Given this list of marker genes VSTM2L, NEBL, KLK10, ALDH1A3, PLEKHA7, SLCO3A1, C1orf74, SLC6A14, CYP4B1, GRHL3, PLAAT3, EPB41L1, CLIC3, KRT78, ADAMTS9, SH3TC2, PINK1, OCLNP1, KRT4, IL1RN, CLDN7, PI3, S100P, APOBEC3A, ARHGDIB, CRCT1, SLC4A11 (solute carrier family 4 member 11), SPRR1A, PSCA, KRT7, KRT23, DAPP1, EPS8L1, TMOD3, ADGRF1, MALL, ELF3, SPRR3, VSIG10, VSIR, ERBB3, EGR3, GRHL1, FAM171B, SLC12A6, DKK1, CTSV, INPP4B, SAMD9, GGT6, A2ML1, TACC1, VGLL1, CST6, SOX9, TRIM2, RHBDL2, DSC2, GDPD3 (glycerophosphodiester phosphodiesterase domain containing 3), FUT1, KRT81, LCN2, CXCL17, MINDY2, ANXA3, RAB11FIP1, RARRES1, C15orf48, MXD1, MYO6, KLK6, GCNT3, CAMK2N1, PDK4, MUC16, GABRP, TUFT1, CRIM1, SLC17A5, TLR1, SLC20A1, MUC15, SIK1, MYO5B, CCN2 (cellular communication network factor 2), MYH14, KRT13 (keratin 13), CEACAM1, FYB1, IKZF2, B4GALT4, CEACAM6, SCEL (sciellin), IGFL1, AZGP1, GAS2L3, DAPK1, SYTL2, ENC1, IVL, EMP1, GPRC5A, VTCN1, PTGS2, DUSP5, STS, AIF1L, here is a description of the gene set: from publication Lin HJ, Zuo T, Lin CH, Kuo CT, Liyanarachchi S, Sun S, Shen R, Deatherage DE, Potter D, Asamoto L, Lin S, Yan PS, Cheng AL, Ostrowski MC, Huang TH (PMID 19074894) Genes downregulated in MCF10A cells (breast cancer) co-cultured with cancer-associated fibroblasts (CAF). The interplay between histone modifications and promoter hypermethylation provides a causative explanation for epigenetic gene silencing in cancer. Less is known about the upstream initiators that direct this process. Here, we report that the Cystatin M (CST6) tumor suppressor gene is concurrently down-regulated with other loci in breast epithelial cells cocultured with cancer-associated fibroblasts (CAF). Promoter hypermethylation of CST6 is associated with aberrant AKT1 activation in epithelial cells, as well as the disabled INNP4B regulator resulting from the suppression by CAFs. Repressive chromatin, marked by trimethyl-H3K27 and dimethyl-H3K9, and de novo DNA methylation is established at the promoter. The findings suggest that microenvironmental stimuli are triggers in this epigenetic cascade, leading to the long-term silencing of CST6 in breast tumors. Our present findings implicate a causal mechanism defining how tumor stromal fibroblasts support neoplastic progression by manipulating the epigenome of mammary epithelial cells. The result also highlights the importance of direct cell-cell contact between epithelial cells and the surrounding fibroblasts that confer this epigenetic perturbation. Because this two-way interaction is anticipated, the described coculture system can be used to determine the effect of epithelial factors on fibroblasts in future studies. species: Homo sapiens Human Gene Set: LIN_SILENCED_BY_TUMOR_MICROENVIRONMENT